Given this list of marker genes REXO4 (NCBI Gene Id 90950), TRIM13, PDE4B, DENND2B, GOSR2, MARK3, SLC7A8, SH3BGRL2, NFKBIE, CRLF3, WNT9B, LARP1, STAT3, VASP, NDST2, OSMR, UTP6, GGT1, TRIM14, CSRNP1, IRAK2, RAPGEF2, SH3BP4, FARSA, GRINA, PIGV, ARHGAP26, NAA25, RNF14, BTG4, TASOR2, FAM241A, BAZ1A, SMIM3, RHOU, PLOD2, RNF34, CPSF2, PARP11, CITED2, GPR87, NUDT13, TMCO3, TEX19, ZNRF3 (zinc and ring finger 3), GLS, SLC4A7, REL, PLK3, MDM2, RAB11FIP1, CAVIN4, SH3GLB1, HDC, HSPA12B, TFAP2E, IFNAR1, ANKRD39 (ankyrin repeat domain 39), PHLDA1 (pleckstrin homology like domain family A member 1), ATAD2B, REEP2, PPP1R15B, NR3C1, BOD1, CGGBP1, ZC2HC1A, ITPRIP, FRMPD3, DHX37, DRAM1, KPNA3, ARID4A, MUSTN1, SECTM1, STAT2, TNF, C1orf56, ACTL9, MTMR7, RGL1, ACTL7B, SMG9, ALDH1A3, SETDB2, VSTM5, RAB9A, SUSD6, ZHX2, GOLGA3, CSRP3, CUTC, NRTN, FCGR1A, ANKIB1 (NCBI Gene Id 54467), SERPINB12, RFX5, ARMCX6, MACIR, PAMR1, PHIP, VCAN, YTHDF1, CASP1, FMR1, HK2, CENPJ, SLC17A3, IFIT1, AKR1C4, FNBP4, PTCH1, PPP2R2A, BCOR, GAP43, PARP9, LHX2 (NCBI Gene Id 9355), ETNK1, ATP9B, VRK2, UBASH3B (NCBI Gene Id 84959), WHAMM, IRF1, BRD10, FBRSL1, SLC22A15, SEC63, PLEKHF2 (NCBI Gene Id 79666), SLC39A14, SNORD89, NAA16, CLCN7, PSMA4, CIAO2B, PPM1K, VPS37B, TMEFF2, RAVER1, IL18BP, NFKBID, STPG4, JUNB, AGPAT1, ASB13, GJA1, SYNE3, PML, ELP5 (NCBI Gene Id 23587), MAPK9, TCF4, UBE2U, PARP8, KAT6A, NAP1L3 (NCBI Gene Id 4675), SOX9, MAPKAPK2, PNP, MAN2A1, PPA1, CDC73, LPAR3, AMBRA1, POU2F2, WDR37, KLHL13, PSMB10, FAM20B, RRP9, TRIOBP, BST1, KLRG1, UBQLN3, WNT5A, FRMD4A, SMG7, PTPN9, TNFAIP3, DNAH12, GTDC1, IGSF9 (immunoglobulin superfamily member 9), ZEB1, CAPN12, CEPT1, CAV3, ZNF799, HSPA1B, TAP2, APAF1, PLCB3, GALNTL5, INPP5B, DGKA, LRP10, HK1, NRP2, PPP4R2, SSMEM1, WARS1, B4GALT5, CSF2, GABPB1, here is a description of the gene set: species: Homo sapiens The recent discovery of the human B1 cells, identified by the expression of CD20, CD27 and CD43 in absence of expression of CD70 and CD69 has been subject of debate. Some studies have raised the possibility that these cells are B cells differentiating towards the plasmablast and plasma cell stage rather than being the human counterpart of murine B1 cells. No further in depth studies have been performed. Therefore, a functional comparison was made between, the proposed B1 cells and plasmablasts. We observed that for several functional characteristics (distribution of isotypes of spontaneously producted antibodies, production of antigen-specific antibodies after vaccination with both T-cell dependent as well as T-cell independent antigen, the proposed B1 cells behaved similar to plasmablasts. In addition, we were able to differentiate the proposed B1 cells in vitro, indicating that they are not from a distinct lineage as the murine B1 cells. Gene expression analysis revealed that these cells cluster between memory B cells and plasmablasts, contradicting them being the genuine human counterpart of murine B1 cells, rather revealing a preplasmablast phenotype. Genes up-regulated in B lymphocytes: naïve versus B1. from publication Covens K, Verbinnen B, Geukens N, Meyts I, Schuit F, Van Lommel L, Jacquemin M, Bossuyt X (PMID 23613519) Human Gene Set: GSE42724_NAIVE_VS_B1_BCELL_UP